The following is a description of a gene set: The immune responses generated by YF-17D by profiling genes in 25 vaccine recipients were accessed at days 1, 3, 7, and 21 post-vaccination compared to pre-vaccination in PBMCs. The immune responses generated by YF-17D by profiling genes in 25 vaccine recipients were accessed at days 1, 3, 7, and 21 post-vaccination compared to pre-vaccination in PBMCs. Genes down-regulated in comparison of unstimulated peripheral blood mononuclear cells (PBMC) 3 days after stimulation with YF17D vaccine versus PBMC 21 days after the stimulation. studied in species Homo sapiens Human Gene Set: GSE13485_DAY3_VS_DAY21_YF17D_VACCINE_PBMC_DN from publication Querec TD, Akondy RS, Lee EK, Cao W, Nakaya HI, Teuwen D, Pirani A, Gernert K, Deng J, Marzolf B, Kennedy K, Wu H, Bennouna S, Oluoch H, Miller J, Vencio RZ, Mulligan M, Aderem A, Ahmed R, Pulendran B (PMID 19029902), and this is the list of marker genes: WNT16, NTF4, TNFAIP6, MME, FAM81A (family with sequence similarity 81 member A), PKMYT1, PLA1A, MC2R, SYT13, AHDC1, AZGP1P1, INSL3, CXCR1, GRM5 (glutamate metabotropic receptor 5), FOXB1, CABP4, ENSG00000281732, TTC23, LRFN5, SLC5A5, ALLC, GPR156, GRIK3, LRRTM1, PGC, HOXB-AS3, TCTE1, FAM135B (family with sequence similarity 135 member B), LGALS14, GOLT1A, C5orf46, ZNF491, POM121L12, KRTAP9-8 (keratin associated protein 9-8), DEFT1P, SMTNL2, PHF24, PACS2, ACTL7A, PEX5L (NCBI Gene Id 51555), ATP1A4, DEFB124, PKLR, PMS2P11, FRMPD1, LINC00589, LINC01539, RASIP1, DLGAP2-AS1 (DLGAP2 antisense RNA 1), ENSG00000230725, PTH2, TP53AIP1, PCDHAC2, H4C1, PRR23E, PON1, NXPE4, AMOTL1, KCNJ11, OR51B5 (NCBI Gene Id 282763), RIMS1, NR2F2-AS1, LUZP4, PHKA1, VSTM2B-DT, A4GNT, KRT84, CCN1, PLA2G10, SLC24A2, NR2E1, FBLN1, ANKRD42, CHRDL2, LINC00642, ZNF548 (zinc finger protein 548), RAB3C, PRDM16, BHLHE22-AS1, TRAV8-3, GSC, GPR137, HOTTIP, PTGIS, LCN15, MAT1A, ALDH1L1, CCNYL7, PRR36, ATP6V0A4, STH, SERPINA9, LINC00626, GABRR2, FAM78B, APOH, IL1RAPL2, LPAL2, EVC, REL-DT, OR52A1, CNR2, MNX1, TAC3, SCN2A, KCNK15, GRIA4, EFCAB5, CA7, NLRP13, MIR3945HG, INTS4P1, CFAP157, BHLHE41, PRSS33, ATN1, CFAP70, JRKL, CDX1, ALX1, OR7E104P, CFAP74, FBXW10B, PRPS1, ILVBL, RPL3L, FRMPD3, TMC1, MMP28, OPTC, LINC00052, MAP3K15, NRSN1, MOBP, SCN10A, LINC01592, CHRNA3, SPINK13, FGF6, PPP1R2C, OR2S2, ACTRT2, CDKN2A-AS1, UCP1, CPN2, RASAL2, EXOSC3, TPRXL, FSHR, VN1R4, RARB, CACNG1, FGF23, TMEM54 (NCBI Gene Id 113452), SLC5A4, ANK2, EPHB3 (EPH receptor B3), HOXC12, DLX5 (NCBI Gene Id 80275), PACRG, GLB1L2, CXCL12, LINC02523, PPP2R3A, FHOD3, TMEM235, PPARG, CAMK2A (calcium/calmodulin dependent protein kinase II alpha), CD300LG, WDR87, GJD3, LRRC52-AS1, AQP4-AS1, PANX2, CCL20, LINC00656, BTNL8, ZNF135, NEBL, MIR124-1HG, FBXL18, ANKRD30BP3, EPOR, LINC01686, LIN9, AVPR1A, THRSP, MYOZ3